Given this list of marker genes LAMB3, SMARCAD1, OCA2, AARS1, TNFRSF10B, IL7, XPC, COL7A1, WRN, CTSC, DKC1, COL14A1, TMC6, TYMS, MMP1, CARS1, GTF2H5, ING1, NAF1, ERCC2, AAGAB, LAMA3, GTF2E2, RSPO1, POLH, DOCK8 (NCBI Gene Id 81704), GJB2, COL17A1, TINF2, BLM, TYR, ERCC3, ATR, MVD, STAT1, KRT14, PSENEN, CDKN2A (cyclin dependent kinase inhibitor 2A), MVK, TERC, UROS, ERCC4, TMC8, SASH1 (SAM and SH3 domain containing 1), XPA, GJB6, RECQL4, SLC17A9, LAMC2, MPLKIP, NLRP1, ERCC5, KRT5 (NCBI Gene Id 3852), GATA1, RNF113A, FERMT1, MC1R (NCBI Gene Id 4157), WNT10A, STAT4, NTHL1, SLX4, NUTM1, BRD4, FDPS, TARS1, ANAPC1, LMNA, CIB1, TERT, DDB2 (NCBI Gene Id 1643), here is a description of the gene set: Human Gene Set: HP_SQUAMOUS_CELL_CARCINOMA studied in species Homo sapiens Squamous cell carcinoma The presence of squamous cell carcinoma of the skin.